The following is a description of a gene set: Mouse Gene Set: GOBP_EXOCYTIC_PROCESS species: Mus musculus The cellular processes that contribute to exocytosis., and this is the list of marker genes: Psen1, Rims2, Ctbp2, Vamp8, Unc13c, Syt9, Unc13b, Snapin, Kcnb1, Nlgn1, Ncam1, Rims3, Stxbp3, Trarg1, Rab44, Syde1, Exoc5, Adora3, Ywhaz, Otof, Rph3al, Cplx3, Cplx2 (complexin 2), Rph3a (NCBI Gene Id 70216), Scrib, Stxbp5, Cacna1b, Pla2g3, Ralb, Stx11, Syt11, Napb, Doc2b, Brsk1, Stx19, Stxbp1, Snap29, Syngr3, Rab3gap1, Exoc6b, Napa, Ppfia3, Syt4, Unc13d, Rims1, Snx4, Exoc2, Doc2a, Stx1a, Cplx4, Exoc1, Syt1, Snap23, Vamp1, Synj1, Stx2, Vamp2, Stx1b, Gnao1, Ykt6, Sytl2, Cplx1, Rab3a, Lyn, Stxbp2 (syntaxin binding protein 2), Vps18, Exoc6, Erc1, Exoc4, Plek, Syt2, Efr3a, Btk, Snap25, Snap47, Exoc3, Grik5, Erc2, Camk2a, Vps11, Cd300a, Pclo, Syt5, P2rx1, Fcer1g, Sv2a, Syk, Osbpl2, Exoc7, Cadps, Slc18a2, Nppa, Prrt2, Syt7, Cadps2, Syt8, Stx4a, Cftr, Doc2g, Snca, Bloc1s6, Rimbp2, Syt13, Rab8a, Septin5, Syp, Tprg1l, Exoc8, Unc13a